The following is a description of a gene set: from publication Cao J, O'Day DR, Pliner HA, Kingsley PD, Deng M, Daza RM, Zager MA, Aldinger KA, Blecher-Gonen R, Zhang F, Spielmann M, Palis J, Doherty D, Steemers FJ, Glass IA, Trapnell C, Shendure J (PMID 33184181) Human Gene Set: DESCARTES_FETAL_STOMACH_CILIATED_EPITHELIAL_CELLS Marker genes curated from the annotated cluster as represented in the Descartes Human Gene Expression During Development database. studied in species Homo sapiens The gene expression program underlying the specification of human cell types is of fundamental interest. The study authors generated human cell atlases of gene expression and chromatin accessibility in fetal tissues. For gene expression, the study authors applied three-level combinatorial indexing to >110 samples representing 15 organs, ultimately profiling ~4 million single cells. The study authors leveraged the literature and other atlases to identify and annotate hundreds of cell types and subtypes, both within and across tissues. Our analyses focused on organ-specific specializations of broadly distributed cell types (such as blood, endothelial, and epithelial), sites of fetal erythropoiesis (which notably included the adrenal gland), and integration with mouse developmental atlases (such as conserved specification of blood cells). These data represent a rich resource for the exploration of in vivo human gene expression in diverse tissues and cell types., and this is the list of marker genes: CFAP96, SPAG8 (sperm associated antigen 8), ROPN1L, ZNF474, SPMIP6, BBOF1, TCTE1, DEUP1, SAXO2, ABCA13, CFAP206, TOGARAM2, ANKFN1, CTXN1, LINC02166, PIH1D2, SPAG17, LDLRAD1, BCYRN1, TUBA4B, CCDC65, ANKRD66, CIMIP2B, MAPK15, AK7, TPPP3, LRRC10B, EFHC2, NWD1, CFAP52, DNAH2, WDR86-AS1, STMND1, ANKRD44-AS1, LRRIQ1, CCDC30, CFAP126, LRRC27, MARCHF10, C7orf57, CIBAR2, ZMYND10, KIAA0825, TMEM190, CFAP46, CES4A, ODAD2, FAM81B, TRAF3IP1, FBXW9, RAB36, TEKT3, HYDIN, THBS3-AS1, CCDC181, DRC7, CFAP90, NEK11, SCGB2A1, LRRC46, WDR90, ATG9B, ZMYND12, RGS22, DLEC1, C10orf67, TTC16, CROCC2, CCDC33, IQCH, LRRC73, CFAP91, SPA17, NEK5, DDX3ILA1, CFAP299, CDC20B, DNAI2, CFAP57, MAT1A, WDR93, CFAP44, DYDC2, KCNE1, FANK1, TTC9-DT, SLFN13, DNAH5, OXTR, TMEM231, SVOPL, KIAA2012, CFAP210, RP1, B9D1, WDR54, ENKUR, CCDC146, ENSG00000181123, PLEKHG7, MYCBPAP, CIMIP1, KIF6 (kinesin family member 6), CFAP58, AK9 (adenylate kinase 9), PPP1R42, VWA3B (von Willebrand factor A domain containing 3B), CCNO, CFAP69, DCDC2B, MAP3K19, CFAP47, DYNLT4, DYNLRB2, FAM216B, STK33, ZBBX, ERICH3, NRAD1, C1orf87, AHI1-DT, RSPH9, TMEM232, MDH1B, NEK2-DT, SPAG6, SAXO4, C22orf15, RSPH10B, CCDC78, C6orf118, SPEF1, LIAT1, LINC01708, CDHR3, LMNTD1, SAMD15, CSPP1, ZDHHC1, FAM227A, IQCD, FAM81A, CCDC170, DNAH10, PRH2, SPATA6L, AK8, NEK10, ZC2HC1C, DNAH3, CIMAP1B, DRC1, DNAI7, CFAP20DC, CFAP74, WDR38, DNAH9, CFAP53, CFAP263, CLXN, PSENEN, CFAP45, TSPAN19, ANKUB1 (ankyrin repeat and ubiquitin domain containing 1), FHAD1, CFAP300, LINC01392, FAM229B, CFAP119, SLC9C2 (NCBI Gene Id 284525), TTC21A, LINC02955, ZNF497 (NCBI Gene Id 162968), TEKT2, CFAP251, DCDC1, CCDC17, CYP4B1, CIMIP6, SNTN, OSCP1, IQUB, IL5RA, ANKMY1, DNAI4, CFAP276, CC2D2A, CATIP, LEKR1, SNRPF-DT, CAPSL, CFAP157, KIF9, EFCAB12, FABP6, CDKN2B-AS1, MB, LINC00589, CFAP43, LCA5L, MORN5, EFHC1, PPIL6, CLUAP1, TMEM212, DNAAF8 (dynein axonemal assembly factor 8), HOATZ, ZNF20, DNAH11, C7orf78, CFAP95, DNAAF11, CCDC60, LRRC71, TTC29, CFAP107, CST6, AGBL2, FRMPD2, HAGHL, TMEM67, CFAP221 (cilia and flagella associated protein 221), TEKT1, RRAD, CFAP70, MNS1, ODF2L, FBXO36, CFAP144, LINC02345, RSPH14, EFHB, TTLL10, DNALI1, CCDC162P, CFAP73 (NCBI Gene Id 387885), CCDC148, SYNPR-AS1, ECT2L, FAM174A, VWA3A, LRRC51 (NCBI Gene Id 120356739), CFAP54, CABCOCO1, PIERCE1, ODAD3, RSPH10B2, TTLL9, PPP1R36, ULK4 (NCBI Gene Id 92216), CFAP418-AS1, CFAP100, DNAAF1, AKAP14, LINC01765, CIMAP3, DNAH12, ADGB (androglobin), SPACA9, FOXJ1, CDHR4, KIF19, CD164L2, DNAJB13, DTHD1, TTC23L, CCDC40 (NCBI Gene Id 55036), MORN2, NME5, EFCAB6, DOC2A, PRR29, RPGR, RWDD3-DT, SPEF2, SPATA18, STOML3, CCDC13, DNAI3, KIF23-AS1, CCNO-DT, BBS5, NME9 (NME/NM23 family member 9), ALDH3B1, ENSG00000263011, CCDC190, RSPH1, DNAH7, DNAH6, ODAD1, SPATA17, ARHGAP39, CAPS, ARMC3, WDR49, GON7, CERKL (NCBI Gene Id 394232), ODAD4, VNN3P, CCDC191, FUZ, GRM5, CFAP65, DRC3, DNAAF3, CFAP77, C8orf34, ANKRD18B, TROAP-AS1, DNAI1, TCTN1, FAM167A-AS1, CSRP3-AS1, ENSG00000258752, CFAP61, LRRC23, ENKD1, CCDC81 (NCBI Gene Id 60494), CFAP184 (NCBI Gene Id 257236)